The following is a description of a gene set: from publication Chen Y, Wang X (PMID 31504780) Genes predicted to be targets of miRBase v22 microRNA hsa-miR-4524a-5p in miRDB v6.0 with MirTarget v4 prediction scores > 80 (high confidence targets). studied in species Homo sapiens Human Gene Set: MIR4524A_5P, and this is the list of marker genes: UBE4B, LAMP3, OOEP, CCNE1, SYDE2, TOX3, SESN1, TMEM100, CDK5R1, KIF2A, SLC35G1, SLC25A37, CDK8, ZNF367, PARD6B, OCRL, ANKS1A, PDZD8, DYNC1LI2, PRDM4, PTPRR, KCNJ2, SEMA3D, CFAP45 (cilia and flagella associated protein 45), CCDC83, SLIT2, PPP2R1B, SLC2A3 (NCBI Gene Id 94827), RAB11FIP2, FCHSD2, PTPRD, NAV1, PTCD3, KIF5C, TAOK1, RICTOR, SEMA6D, CPEB2, NHLRC2, WIPI2, KCNN4, DMTF1, NUP50, ASH1L, VEGFA, CHAC1, PAFAH1B1, SMURF1, SEC24C, MOB4, SEC24A, CBFA2T3, AK4 (NCBI Gene Id 387851), DEPDC4, SIRT4, HMGA2, ZMAT3, PAPPA, TBL1XR1, C12orf76, CMPK1, SEL1L3, TENM2, CDC14A, GNAI3, GAREM1, RECK, ZFHX3, CAPZA2, CMC4, FBXW7, ATXN2, SOCS6, RIMKLB, LIMS4, KLHL2 (NCBI Gene Id 11275), MED26, SLC12A2, RFX3, ZBTB39, UBR3, CREBRF, CD2AP, HSPA8, EMC4, GABRA2, SALL3, GPR63, C1orf21, ACTR2, ZFHX4, SLC11A2, EPHB2, NAA15, IFT74, KDSR, DENND1B, HECTD1, PNPLA6 (patatin like phospholipase domain containing 6), NFE2L1, PACRG (parkin coregulated), CCDC6, IPO7, PLEKHA1, DCLK1, USP25, PLAG1, DRAM1, SLC20A2, USP12, GSTCD, GLCE (NCBI Gene Id 90998), CDK17, CACNA1E, KANK1, TSPYL2, PNRC2, MGAT4A, CBX4, UHMK1, N4BP1 (NCBI Gene Id 9683), USP31, ST8SIA3, ACSL4, SMURF2, CCNJ, MTAP, QKI, TMCC1, MAPK8, ALDH1A3, G2E3, ZNRF3, KCNQ5, MYB, CCND2, GATA2 (NCBI Gene Id 84724), TLK1 (NCBI Gene Id 9874), TMEM183A, RUNDC3B, CDC37L1, NPTN, UBN2 (ubinuclein 2), CBX2, PIP4P2, CDHR1, DESI1, PTPN3, PROX1, SMAD7 (NCBI Gene Id 4092), WEE1, MEOX2, NSD2, MPDZ, STXBP5, ZBTB44 (NCBI Gene Id 29068, zinc finger and BTB domain containing 44), CACUL1, MOB3B, ORMDL1, BCAP29, SREK1, RPS6KA6, TMEM245, CDC27, FAM81A, BMPR1A, PURG, ELL2, EFCAB5, NDP, ZC3H13, SPRED1, FGF7, MAP3K7, MOV10, DNAJA2, RASGEF1B, PAM, GALNT13, KIF21A, CREB5, VSX1, ISLR, GOLGA1 (golgin A1), STK33, PPP1R11, NRN1, ATP7A, HECTD4, AKT3, CCND1, STOX2, SLC2A14, EPHA7, ARMH4, ADAMTS3, TMEM74B, SALL1, SRPRA, RNF144B, LIMS3, BTAF1, ARHGAP20, TNFSF13B, BTRC, MAP2K1, KIF23, ARHGAP32, UNC13A, CDCA4, SLC30A8, GHR, PTH, MYRIP, CYP26B1, CYP2S1, TNRC6B, PABIR1, ZNF697, FGF2, AAK1 (AP2 associated kinase 1), OMG, ZBTB46, SLC24A3, ARL2, UBQLNL, NOS1, PTPN4, ZNF622, YTHDC1, ACVR2A, CPEB3, TMC7, RREB1, PPP2R5C, UNC80, FRY, VPS33B (NCBI Gene Id 55513), LRRK1, IKBKB